Given this list of marker genes PGLYRP2 (NCBI Gene Id 94295), LYG1, PGLYRP4, LYG2, PGLYRP3 (peptidoglycan recognition protein 3), PGLYRP1, here is a description of the gene set: Human Gene Set: GOBP_PEPTIDOGLYCAN_METABOLIC_PROCESS The chemical reactions and pathways involving peptidoglycans, any of a class of glycoconjugates found only in bacterial cell walls and consisting of long glycan strands of alternating residues of beta-(1,4) linked N-acetylglucosamine and N-acetylmuramic acid, cross-linked by short peptides. studied in species Homo sapiens